The following is a description of a gene set: The organization process that preserves a neuron projection in a stable functional or structural state. A neuron projection is a prolongation or process extending from a nerve cell, e.g. an axon or dendrite. Human Gene Set: GOBP_NEURON_PROJECTION_MAINTENANCE species: Homo sapiens, and this is the list of marker genes: APP, MAP1A, PRNP, EPHB2, INS, NMNAT1, DCTN1, INSR, NMNAT2, KIFBP, PSEN1, ADCY10, ABCD1, NMNAT3, ATP1A3, ABCD2